The following is a description of a gene set: Human Gene Set: GSE2128_CTRL_VS_MIMETOPE_NEGATIVE_SELECTION_DP_THYMOCYTE_NOD_DN Genes down-regulated in NOD CD4 CD8 double positive thymocyte transgenic for the BDC2.5 TCR incubated with no peptide 0h versus NOD CD4 CD8 double positive thymocyte transgenic for the BDC2.5 TCR incubated with mimetope negative sel 16h. from publication Zucchelli S, Holler P, Yamagata T, Roy M, Benoist C, Mathis D (PMID 15780994) studied in species Homo sapiens Fetal thymic organ culture (FTOC) DC2.5 CD4+CD8+ thymocytes from B6g7 or NOD background. 0 or 16 hour after addition of the BDC mimitope, and this is the list of marker genes: RNF181, FAM110B, NDUFC2, NFE2, SPTAN1, ZNF667, FAM50A, INTS9, SNRNP200, HSD11B1, DSG1, SUFU, FAT4 (FAT atypical cadherin 4), PDGFC, TLL1, TTC9C, CCL17, CDK5, IL18BP, MAOA, PLOD1, CTDP1, LMNB2, STOML3, TBX19, ELAVL4, ALDH2, PXDC1, ARHGAP25, EPOP, MAPKAPK5, TNFRSF4, PLEKHO2, UBTF, TSPAN33, MFHAS1, EEPD1, H2BC11, MEX3B, OLFM2, TMEM250, BORCS5, FADS2, MRPL48, CARD9, MINK1, PDE1A, TSC2, GTF3C4, EHD2, ATG9B, SLC23A3 (solute carrier family 23 member 3), SNX17, KMT2D, MAF, MMP21, UBE2M, ZBED1, ZFP36L1, PACS1, CECR3, PI4K2A, HIP1, SLC4A7, DNAH10, WNT7A, ZZEF1, CLTB, CD209, CCDC137, COMMD1, AIFM1, PDGFB, PIEZO1, BLTP2, PPEF1, EPHA4, SLX4, CPT1A, ENG, CCL22, ZNF568, POLRMT, USP28, ADGRG6, POGLUT3, FAM89B, CACYBP, SPHKAP (SPHK1 interactor, AKAP domain containing), STK11, INTS7, STAB1, ANKRD18A, CCL5, RGR, NPRL2, ZNF442, SILC1, ZNF746, SLC47A1, JUNB (NCBI Gene Id 90482), KLF2, AP2M1, ORAI1, C11orf21, ZNF138, SMG1P1, HSPB1, PSG4, QSOX1, SLCO3A1, NISCH, CYYR1, ARL4C, CBX6, TMEM132D-AS1, LRRC69, CGN, TKT, GFRA2, LINC02458, HPD, PPP1R9B, GAL3ST4, SLC38A7, RERE, CD200R1, DYRK2, MLST8, DCANP1, RABEPK, GGTA1, CLEC4G, C2CD2L, RECQL5, IRF4, NPIPA1, RAB8A, UQCR10, SBF1, TRIB2, NFIC, APBB1IP, KCNK6, ST6GALNAC1, SPINT2, ZER1, APEX2, EXT1, NCAPH, SYNGR2, PRADC1, ZC3H3, TTLL12, CCL26, ALOX15, NFXL1, ACO2, TMEM71, TNFRSF10A-DT, DPH3P1, KISS1R, EMB, GAS2L3, AKT1S1, TP53, MNT (MAX network transcriptional repressor), H2AC14, ACAD9, ZBTB46, HAPSTR2, APOO, MCRIP2, MBNL1-AS1 (NCBI Gene Id 401093), LINC00705, LINC01252, JADE1, LINC00687, TMT1A, C17orf58, ISM2, NUDT16L2P, BACE1, CDC42BPB, MORC4, LRATD1, LEO1, HTT, NAALAD2, APOL4, MGME1 (mitochondrial genome maintenance exonuclease 1), COQ9, MCUR1, PALLD, NOTCH3, TBC1D17